The following is a description of a gene set: species: Mus musculus Mouse Gene Set: GOMF_GABA_A_RECEPTOR_ACTIVITY Combining with the amino acid gamma-aminobutyric acid (GABA, 4-aminobutyrate) to initiate a change in cell activity. GABA-A receptors function as chloride channels., and this is the list of marker genes: Gabrg1, Gabra1, Gabrb3, Gabra5, Gabrg2, Gabrp, Gabra4, Gabra3, Gabra2, Gabrr2, Gabrb2, Gabrb1, Gabrr3, Gabrg3, Gabrq, Gabrr1, Gabre, Gabrd, Gabra6